Given this list of marker genes Crebbp, Cdc73, Larp7, Ccnb1, Rad51b, Tgfb1, Phb2, Lsm11, Dyrk3, Rgcc, Fbxo5 (F-box protein 5), Gli1, Rdx, D1Pas1, Sin3a, Plcg2, Cenpj, Ccnd2 (cyclin D2), Cul4a, Ezh2, Cdc20, Egfr (NCBI Gene Id 13649), Kmt2e, Cul3, Chek2, Prap1, Anapc11, Mad2l1bp, Cdc25b, Mtbp, Wnt10b, Cpsf3, Pagr1a, Mblac1, Ccnb1-ps (cyclin B1, pseudogene), Tert, Tbx1, Crnn, Lsm10, Stox1, Cdc25c, Ska3, Ube2e2, Neurog1, Birc5, Ccnd3, Npm1, Apex1, Brd4, Paf1, Mdm2, Mapk15, Rrm2b, Akt1, Adamts1, Ccnd1, Cdc7, Ube2c, Klhl18 (kelch-like 18), Trp63, Pkp3, Cdca5, Ska1, Aurka, Atad5, Adam17, Ppp1r10, Hyal1, Mir124a-3, Vps4b (vacuolar protein sorting 4B), Rptor, Nsmce2, Anapc5, Stxbp4, Tbx2 (T-box 2), Ankrd17, Tmod3 (tropomodulin 3), Mad1l1, Smarcd3, Ddr2, Mta3, Cul4b, Pbx1, Mir124a-2 (NCBI Gene Id 723950), Cdk4, Hspa2, Tfdp1, Cdc16, Dtl, Eif4g1, Plrg1, Fgf10, Kcna5, Stil, Mepce, Fam83d, Ccne1, Sass6, Anxa1, Cdc23, Rb1, Ddx3x (DEAD box helicase 3, X-linked), Camk2d, Rcc2, App, Rpl17, Cyp1a1 (NCBI Gene Id 13076), Aif1 (allograft inflammatory factor 1), Cenpe, Csf1r, Anp32b (NCBI Gene Id 67628), Ccne2, Lmnb1, Mir124a-1, Dbf4, Plcb1, Anapc7, Rrm1, Rad51c, Rab11a, Cdc25a, Cdk1, Rrm2, here is a description of the gene set: species: Mus musculus Any process that activates or increases the frequency, rate or extent of cell cycle phase transition. Mouse Gene Set: GOBP_POSITIVE_REGULATION_OF_CELL_CYCLE_PHASE_TRANSITION